The following is a description of a gene set: The series of molecular signals initiated by the accumulation of normal or misfolded proteins in the endoplasmic reticulum and leading to activation of transcription by NF-kappaB. studied in species Mus musculus Mouse Gene Set: GOBP_ER_OVERLOAD_RESPONSE, and this is the list of marker genes: Trp53, Ins2, Atg10, Selenos, Bid, Hspa5, Ccdc47 (NCBI Gene Id 97906), Ppp1r15b, Tmco1, Ddit3, Wfs1, Bcl2l11, Gsk3b, Eif2ak3